The following is a description of a gene set: A cell junction that forms a connection between a cell and the extracellular matrix. Mouse Gene Set: GOCC_CELL_SUBSTRATE_JUNCTION species: Mus musculus, and this is the list of marker genes: Dlc1, Lama3, Lpxn, Actr3, Itgbl1, Cpne3, Ppfia1, Dcaf6, Pik3r2, Atat1 (alpha tubulin acetyltransferase 1), Itga5, Sdc4, Stard8, Wtip, Itgav, Fam107a, Map2k1, Pxn, Arhgap31, Pak2, Armc5, Pdlim7, Tns4, Dctn4, Col17a1, Tada1, Tnfsf13b, Tln1, Limk1, Fermt1, Lmln, Nrp1, Mapre2, Rala, Tln2 (NCBI Gene Id 70549), Rhou, Lims1, Fermt3, Dmd, Actn3, Enah, Cbl, Cttn, Zfyve21, Nedd9, Apbb1ip, Actb, Adam17, Tgfb1i1, Crb1, Nrap, Map4k4, Cyba, Itgb2, Itgb5 (NCBI Gene Id 16419), Srp68, Vasp, Il1rl1 (NCBI Gene Id 17082), Tns3, Syne2, Itgb7, Trpv4, Ssh2, Arl14ep, Tesl1, Clasp2 (NCBI Gene Id 97514), Actn1, Cav3, Itgb8, Msn, Actn2, Pak1, Cfl1, Zyx, Ezr, Ptk2b, Lpp, Ptprc, Usp33, Rdx, Arhgef7 (Rho guanine nucleotide exchange factor), Iqgap1, Ptk2, Arpc2, Flrt3, Itga11, Itga1, Src, Itga2b, Actn4, Sorbs1, Nphs1, Il16, Tns1, Ajuba, Zfp185, Klf11, Nexn, Xirp2, Bcar1, Sorbs2, Shroom4, Cav1, Coro2b, Focad, Ubox5, Fermt2, Misp, Flnb, Map2k2, Tes, Lcp1, Fblim1, Rexo2, Bloc1s6, Avil, Ptpn12, Mapre1, Shc1, Cav2, Gfral, Phldb2, Asap3, Plec, Parvg, Itgb1bp1, Gak, Alox8, Slc6a4, Peak1, Lima1, Svil, Eppk1, Neurl2, Itga6, Gsn, Erbin (Erbb2 interacting protein), Zfp384, Sh3kbp1, Mdc1, Prune1, Irf2, Thsd1, Srcin1, Epha2, Pgm5, Cass4, Smpx, Keap1, Parvb (parvin, beta), Ilk, Limd1, Itga7, Palld, Bcar3, Sorbs3, Fes, Oprm1, Afap1, Dag1, Xirp1, Arhgap24, Flrt1, Rsu1, Lasp1, Sdcbp, Itgb1, Vcl, Dixdc1, Evl, Grb7, Mapk1, Itgb3, Nox4, Jak2, Git1, Pdpk1, Actg1, Tm4sf20 (transmembrane 4 L six family member 20), Slc9a5, Layn, Capn2, Epb41l5, Parva, Alkbh6, Ambra1, Trip6, Clasp1, Atp6v0a2, Nme2 (NME/NM23 nucleoside diphosphate kinase 2), Abcb4, Ptpra, Tesl2, Tns2, Adgrb1, Flrt2, Cib2, Hmcn1, Arhgap26, Arl2, Itgb6, Wasf1, Mapk3, Tle2, Efs, Dst, Itga2, Tek, Pip5k1c, Itgb2l, Senp1, Hck, Flii, Myh9, Synpo2, Prag1, Dnd1, Itgb4, Aif1l, Lims2